The following is a description of a gene set: Any process that stops, prevents, or reduces the rate of leukocyte degranulation. species: Homo sapiens Human Gene Set: GOBP_NEGATIVE_REGULATION_OF_LEUKOCYTE_DEGRANULATION, and this is the list of marker genes: BCR, CD84, RABGEF1, NCKAP1L, HLA-F, IL13RA2, FCGR2B, LGALS9, SPI1, FOXF1, CCR2, CD300A, CEACAM1